Given this list of marker genes PDGFRB, EP300, CREBBP, COL17A1, MAP3K7, AEBP1, ATP7A, APC, LEMD3, COL7A1, OCRL, NOTCH3, FLNA, here is a description of the gene set: Human Gene Set: HP_KELOIDS Keloids species: Homo sapiens